Given this list of marker genes Aurkb, Becn1, Hnrnpu, Cdca8, Sirt1, Kat2b, Kat5, Incenp, Spag5, Numa1, Dync1h1, Birc5, Cdk1, Ttl, Mad1l1, here is a description of the gene set: studied in species Mus musculus Mouse Gene Set: GOBP_REGULATION_OF_METAPHASE_PLATE_CONGRESSION Any process that modulates the rate, frequency, or extent of metaphase plate congression, the alignment of chromosomes at the metaphase plate, a plane halfway between the poles of the spindle.